Given this list of marker genes Setx, Scaf4, Zmpste24, Scaf8, Per2, Wnk1, here is a description of the gene set: Any process that modulates the frequency, rate, extent, or location of DNA-templated transcription termination, the process in which transcription is completed; the formation of phosphodiester bonds ceases, the RNA-DNA hybrid dissociates, and RNA polymerase releases the DNA. Mouse Gene Set: GOBP_REGULATION_OF_TERMINATION_OF_DNA_TEMPLATED_TRANSCRIPTION species: Mus musculus